The following is a description of a gene set: species: Mus musculus electronically inferred by orthology from the curated human pathway This event has been computationally inferred from an event that has been demonstrated in another species.<p>The inference is based on the homology mapping from PANTHER. Briefly, reactions for which all involved PhysicalEntities (in input, output and catalyst) have a mapped orthologue/paralogue (for complexes at least 75% of components must have a mapping) are inferred to the other species. Reactome Pathway: RHO GTPases activate CIT part of: RHO GTPase Effectors, and this is the list of marker genes: Rhob, Dlg4